The following is a description of a gene set: Human Gene Set: GOBP_NUCLEOSIDE_DIPHOSPHATE_METABOLIC_PROCESS The chemical reactions and pathways involving a nucleoside diphosphate, a compound consisting of a nucleobase linked to a deoxyribose or ribose sugar esterified with diphosphate on the sugar. studied in species Homo sapiens, and this is the list of marker genes: AK1, GIT1, RRM1, AK4, NCOR1, PFKFB2, FOXK1, PRKAA2 (NCBI Gene Id 5563), GAPDH (glyceraldehyde-3-phosphate dehydrogenase), NUDT18, OGT, FLCN, PGAM2, HDAC4, PGM1, LRGUK, PRKAG2, RRM2, CARD11, PGK2 (NCBI Gene Id 5232), PFKFB3, AK2, HKDC1, PFKP, MLXIPL, ENTPD1, ENTPD2, SLC4A1, GALK1, OGDHL, HK2, PGK1, NUDT9, MLST8, GAPDHS, DDIT4, EIF6, AK5, CMPK2, ENO1, ACTN3, HK3, DHTKD1, PPP2CA, HTR2A, EP300, NUPR1, DLG1 (NCBI Gene Id 1739), MFSD8, SLC2A6, CMPK1 (NCBI Gene Id 51727), ZBTB20, CAD, NUDT5, SRC, ENTPD4, TJP2, PKM, JMJD8, ADPGK, BAD, AK9, P2RX7, GCK, RRM2B, AK3, CBFA2T3, UCHL1 (ubiquitin C-terminal hydrolase L1), GUK1, PFKM, UMPS, BCL2L13, COL6A1, MAGI3, MPP1, IGF1, APP, HIF1A, ARNT, ZBTB7A, TRIM63, PRXL2C, PRKAG3, DLG2, TIGAR, GPI, OGDH, LDHA, PFKFB1, PPARA, INSR, DHODH, ENTPD8, FKRP, LIPA, ARL2, IFNG, ENTPD5, INS, NT5E, PRKAG1, ALDOC, ALDOA, RPTOR, PSEN1, ENO4, PRKAA1 (NCBI Gene Id 5562), PFKL, TREX1, PKLR, ALDOB, ENO3, SIRT6, KAT2B, GPD1, IER3, FOXK2, SLC4A4, FBP1, BPGM, PGAM1, PRKACA, MTOR, DTYMK, PGAM4, STAT3, ENO2, MTCH2, TPI1, HK1, ENTPD3, NUDT7, ENTPD7, UCP2, CASK